Given this list of marker genes Nr6a1, Bhlhe41, Ikzf4, Ube2g1, Ptpn7, Klc2, Sgpl1, Sema4c, Gal3st2, Ceacam1, Pcgf6, Zbtb7a, Blzf1, Ndufs4, Vps4b, Sema4b, Sh3bp5l, Prdm1, Osbpl9, Ier3ip1, Pafah1b1, Lin28a, Rbm7, 2610528J11Rik, Shtn1, Zfp523, Plxna1, Ctnnal1, Slc25a35, Suv39h1, Sptb, Dvl1, Nhsl3, Xirp1, Bag4, Ppp2ca, Ppp2r5c, Zfyve1, Hdac3, Trp53inp1, Trem6l, Grk4, Atp11a, Klhl24, Nipal4, Eaf1, Crb2, Irf4, Tbc1d8b, Nim1k, Nin, Tor2a, Npl, Dennd6a, Ercc6l2 (excision repair cross-complementing rodent repair deficiency, complementation group 6 like 2), Smurf1, Vdr, Fam83h, Tspan12, Abhd6, Cln6, Mfhas1, Acads (NCBI Gene Id 493130), AU040320, Mfsd9, Dus1l, Cacna1b, Cdr2l, Cbx7, Kmt5c, Tnfaip3, Rora, Hif1an, Tgoln1, Galnt5 (NCBI Gene Id 246134), Dhx33, Necab3, Tada3 (transcriptional adaptor 3), Mapre2, Abtb1 (NCBI Gene Id 80283), Sbno1, Atxn1, Plekhm3, Tafazzin, Scn4a, Bmf, Ccnj, Hic2, Arid3a, Dicer1, Ttc7, Daam1, Zbtb34, Cdc42bpg, Zdhhc9, Sec14l2, Ebf4, Frmd5, Retreg2, Grsf1, Ino80d (NCBI Gene Id 329170), Ubr7, Eif1ad, Tle3, Podxl (NCBI Gene Id 27205), Prdm2, Ninl (NCBI Gene Id 78177), Rfxank, Man1b1, Dock3, Dynlt3, Tjap1, Tmem161b, Tmem72, Ahrr, Mcl1, Enpep, Nbeal2, Prtg, Zswim5, Grhl1, Slc6a17, Trim71, Chtf8, Zfp488, Cgn, Jade2, Gpatch8, Lin28b, Fut1, Cgref1, Rhoq, Nup210, Itga8, Galnt14 (NCBI Gene Id 71685), Prss33, Syvn1, Fbxw4 (NCBI Gene Id 30838), Nfkbib, Bet1, Ppm1h, Mlf2, Slc25a15, Dnajc14, Ncan, P2rx4, Tmtc2, Was, Triap1, Brip1 (BRCA1 interacting protein C-terminal helicase 1), Acer2 (alkaline ceramidase 2), Mobp, Vps37b, Ovol1, Borcs6, Cdk19, Mamdc2, Casp2, Sertad3, Kcnk10, Rfx3, Pi4k2b (phosphatidylinositol 4-kinase type 2 beta), Gga2, Eif4ebp1, Ppat, Lclat1, Mtf1, Golga5, Glb1l2, Hapln1, Cyth1, Anpep, Slc35a4, Gtpbp2, Cdc42se1, Nkapd1, Mfsd13a, Sel1l, Grb10, Sstr3, Neu1, Tent5a, Zbtb37, Bak1, Bap1, Tmem120b, Abcc5, Nrm, Cntd1, Nckap5l, Sh3tc2, Ajuba, Cdc37l1, Tmem25, Cdk16, Ttc29, Lhx8, Kcnip3, Bnip2, Gal3st2c, Tmprss13, Rufy3, Serpinb9d, Scara5, Crem, Zfp518a, Eva1a, Abhd3, Tbc1d1, Rbak, Cyp24a1, Speg, Dtx4, Fam118a, Lrp4, Elovl6, Pcsk7, Cyyr1, Lif, Sarm1, Alpk3, Zscan29, Phactr3, Gpr153, Tnfsf4, Zfp62, Slitrk6, Cnnm1, Il16, Zswim6 (zinc finger SWIM-type containing 6), Ankrd50, Stard13, Msrb3, Alg6, Zfp704, Rasgef1a, Kctd21, Diras1, Tmem132e, Ptpn1, Stat3, Ier2, Rbm20, Kcna1, D17H6S53E, Scn2b, Lfng, Kbtbd13, Il6ra, Khnyn, Rap1a, Retreg3, Abcb11 (ATP-binding cassette, sub-family B member 11), Ppp4r3a, Arid3b, E2f2, Gcnt1, Samd10, M6pr, Kcns3, Slc39a9, Dram2, Cdh5, Tril, Orc2, Klf13, Ulk3, Zfp408, Osgep, Lrrc10b, Scarb1, Sema4d, Map3k11, Myt1, Ist1, Scgb1b30, Fam234b, Usp38, Lactb, here is a description of the gene set: studied in species Mus musculus from publication Chen Y, Wang X (PMID 31504780) Genes predicted to be targets of miRBase v22 microRNA mmu_miR_125a_5p in miRDB v6.0 with MirTarget v4 prediction scores > 80 (high confidence targets). Mouse Gene Set: MIR_125A_5P